The following is a description of a gene set: studied in species Mus musculus This event has been computationally inferred from an event that has been demonstrated in another species.<p>The inference is based on the homology mapping from PANTHER. Briefly, reactions for which all involved PhysicalEntities (in input, output and catalyst) have a mapped orthologue/paralogue (for complexes at least 75% of components must have a mapping) are inferred to the other species. Reactome Pathway: Regulation of TP53 Degradation electronically inferred by orthology from the curated human pathway part of: Regulation of TP53 Expression and Degradation, and this is the list of marker genes: Trp53, Rictor, Cdk1, Rps27a, Chek2, Daxx, Ubb, Pdpk1, Ppp2r1b, Ccna1, Ccng1, Phf20, Sgk1